The following is a description of a gene set: species: Mus musculus Mouse Gene Set: MIR_466I_5P from publication Chen Y, Wang X (PMID 31504780) Genes predicted to be targets of miRBase v22 microRNA mmu_miR_466i_5p in miRDB v6.0 with MirTarget v4 prediction scores > 80 (high confidence targets)., and this is the list of marker genes: Cd84, Mymk, Rhbdd1, Scaf11, Ddi2, Cnot7, Chst11, Slc8a3, Pdxk, Dcx, Rab11fip4, Irf2bp2, Clec4g, Zfp612, Fbxo31, Lbp, Ilrun, Tc2n, Gm14151, Slc4a8, Slc25a12, Nbeal1, Dusp7, P2ry13, Krt222, Triobp, Nufip1, Tvp23a, Pou3f2, Bach2, Asxl2, Hmga2 (high mobility group AT-hook 2), Ralb, Rasa2 (NCBI Gene Id 71394), Ms4a5, Pcdhgb6, Mdm2, Sowahb, Pcdhga3 (protocadherin gamma subfamily A, 3), Esf1, Pcdhgb7, Atrn, Has2, Zfp994, Scn8a, Slc10a2, Stxbp5, Slc25a21, Rara, Ccdc71l, Onecut2, Slc6a1, Ado, Pld5, Cnga4, Chic2 (cysteine-rich hydrophobic domain 2), Kirrel3, Zfp747, Esr2, Gm14325 (NCBI Gene Id 329575), Rbm34, Cask, Dhx40, Fam149b, Msrb3, Cyp4a31, Gabrb2, Egfl6, Dhdh, Unc5c, Prdm12, Lin7a, Wipf2, Spin1, Deptor, Acot2, Rab18, Camk1d, Rims2, Ccna2, Optc, Ogdh, Chrnb4, Plac9, Chd7, Septin11, Ttc38, Mtmr12, Hoxc13, Flrt1, Creb3l1, Snai2, Sema5b, Lcp2, Stxbp4, Pcdhga2, Atxn1, Cd300ld, Uvssa, Rnf44, Lrtm2, Cacna1e, Itga9, Pde10a, Rab6b, Sptlc2, Ddx19b, Kcnmb1, Sv2a (synaptic vesicle glycoprotein 2a), Acsl4, Cfap97, Vezt, Slc37a1, Homer2, Celf4, Onecut3, Cyth3, Ddo, Nqo2, Metrnl, Tmem236, Actr1b, Thsd4, Slc35a3, Ank2, Creg1, Tyw3, Pou2f2, Fubp1, Unc93a, Rfx3, Kcnip3, Smarca2, Peak1, Siah2, Myorg, Bltp3b, Apba1, Emx2, Sod2, Aptx, Dgkg, Sh2d2a, Ugt2b34, Oprm1, Xrcc3, Ubfd1, Zfp696, Vapb, Sbk3, Srgap3, Ttll1, Prdm6, Tmem132b, Dnase1l3, Glis3, Asap3, Slco2a1, Mr1, Acss1, D630003M21Rik, Rasal2, Gas2l3, Htt, Ptchd1, Mbnl3, Jmy, Trub2, Xylb, Acp3, Baiap2, Fgf23, Tmem150c, Rabl2, Pank1, Ptch2 (NCBI Gene Id 19207), Pcdhga10, Psd3, Tacr1, Zfp92, Cdh6, Ift57, Depdc5, Cdh20, Tgfa, Mapk6, Bgn, Jmjd8, Hnrnpa0, Srp9, Cd47, Man1c1, Zfp318, Ehd4, Sdf4, Ackr4, Cd99l2, Iglon5, Dlgap4, St8sia1, Galntl6, Pcdhgb1 (NCBI Gene Id 93699), Trim67, Mnt, Zfp266, Tnfrsf11a, Fzd3, Sp9, Vtcn1, Rab11fip1, Wscd1, Smyd3, Riok3, Gjc3, Prex2, Myo5a, Alox8, Baz2b, Kcnj1, Pcdhgb2, Nalf1, Frmd5, Capn6, Plxna2, Macroh2a2, Gm6710, Elavl4, Tead1, Pacsin2, Pou4f2, Enpp1, Tmem52b, Zfhx3, Trim30d, Zfp827, Ggt5, Ttc12, Arhgap26, Cldn34c1, D430019H16Rik, Pou6f1, Cmklr1, Pcdhga8, Gm3604, Zmat4, Bend3, Vsig10l, Ptpre, Zmiz1, Slc22a8, Wdr59, Irag1, Zfp39, Mbtd1, Otx1, Slc1a2, Sema5a, Kcnj15, Adhfe1, Stxbp5l, Mllt3, Prkca, Fermt1, Mrpl19, Lgals12, Prss42, 2510009E07Rik, Zfp607b, Nkain3, Dctd, Dapp1, Ubxn2b, 1110059E24Rik, Plp1, Sp100, Bmpr2, Liph, St8sia3, Elp4, Csmd1, Acvr2b, Egr3, Tamalin (trafficking regulator and scaffold protein tamalin), Atm, Adamts17, Vti1a, Cp, Usp25, Gadl1, Ebf3, Vamp5, Lcorl, Snrpn, Foxk1, Nrxn1, Gas2l1, Kpnb1, Treml2 (triggering receptor expressed on myeloid cells-like 2), Mlxip, Zfp831, Gria3, Cerk, Gask1a, Gucy2e, Kat6a, Ehd3, Tmem151b, Cryz, Tgfbrap1, Garem2, Ap1ar, Samd7, Hivep3, Slc31a2, Fsd1l, Zfp488, Kmt5b, Foxn1, Il1rap, Slc8a1 (solute carrier family 8 (sodium/calcium exchanger), member 1), Fam186b, Flt4, Adgrf5, Eif4e, Gabrq (NCBI Gene Id 57249), Vangl1, Fbrs, Wdr46, Gcnt4, Frk, Zfp663, Ostm1, Zfp606, Megf8, Rhobtb1, Gna13, 9330159F19Rik, Spx, Fam174b, C5ar2 (complement component 5a receptor 2), Pcdhgb8, Arih1, Gm4925, Snx12, Cstad, Septin6, Enpp6, Zfp691, Tpgs2, Slc38a6, Slc2a12, Rimkla, Tnfrsf13c (NCBI Gene Id 72049), Gm14434, Foxa1, Pitpnb, Nxpe3, Epha7, Cacna1c, Tfap2b, Gtf2h2, Ggact, Pdik1l, Clptm1, Alkbh7, Pogk, Chmp1b2, Adra1b, Pgbd1, Svip, Nrk, Mrps25, Pcdhga12, Bicd1 (NCBI Gene Id 319962), Pck2, Zfp365, Nkain2, Map3k7cl, Ceacam18, Pura, Gcnt1, Cacna2d4, Itsn1, Lyrm9, Bcl2l11, Dnai4, Polr3b, Znrf3, Rrm2b, Sox5, Peg3, Zfp37, Cyp2j12, Tti1, Tmod2, Glyr1, Slco3a1, Mfap3l, Oacyl, Smpd4, Lyz3, Nrip3, Ythdc2, Nrp2, Ccdc85a, Rab7, Unc13b (NCBI Gene Id 230089), Zfp74, Ermap, Cyp2g1, Ajap1, Brwd3, Ccdc115, Mbtps2, Prim2, Trpc6, Methig1, Tacc1, Arhgap25, Slc6a6, Rab9, Neurod2 (NCBI Gene Id 18013), Zdhhc21, Kcng3, Rabgef1, Elfn2, Rgs9bp, Rpp25, Trpm3, Rspo1, Nkap, Cfap74, Stk32a, Tafa3, Rfk, Eif2b3, Pik3r5, Trim60, Oxsm, Ncam1, Nt5e (5' nucleotidase, ecto), Vps37a, Dcdc2a, Gulp1, Pafah1b1, Dixdc1, Iars1, Crebl2, Srf, Cd19, Peli2, Acot4, Tafa1, Calcoco1, Pfkp, Fam169b, Muc4, Akap13, Aldh8a1, Mettl27, Prps1l1, Zc3h12d, Pou3f4, Desi2, Gatc, Borcs8, B4galt5, Gng2, Mdga1, Trim36, AI429214, Zfp91, Ago3, Ppp1r9a, Col13a1, Dlgap2, Barhl2, Asah2, Fndc7, Gnal, Zfp113, Adarb2, Terf2ip, Prkcg, Sema6a, Lrrc61, Ap3s2, Cradd, Rad18, Nr4a2, Aak1, Coq8a, Slc7a8, Vps33a, Mrap, Tmem18, Ms4a4c, 3425401B19Rik, Wars2, Plppr3 (phospholipid phosphatase related 3), Wiz, Yipf6, Golm2, Cplx2, Dph6, Wrn, Tsn, Dkk1, B4galt6, Prelid3a, Pcdhgb4, 2810021J22Rik, Gpr45 (NCBI Gene Id 98649), Apela, Hook3, Vegfb, Anks1b, Meis2, Zfp575, Nufip2, AW554918, Paics, Zbtb7b (zinc finger and BTB domain containing 7B), Rit2, Evi2b, Slc35e2, Mobp, Vsnl1, Kif5a, Slmap, Cnpy3, Cd2ap, Igsf6, Ctse, Ascl4, Dcakd, Zfp810, Prox1, Trip12, Spef2, Zyg11b, Garre1, Atg10, Slamf1, Ngfr, Erg, Iqgap2, Gm2026, Rorb, Zfp276, Slc25a31 (NCBI Gene Id 73333), Arid1b, Fbxw5, Cd27, Zfp446, Nfya, Stambp, Dnaaf5, L1cam, Sowaha, Kif1a, Pof1b, Il18r1, Magee2, Olig2, Scn5a, Grk3, Prokr2, Ttll7, Napepld, Npr3, Hycc2, Dhfr, Rusf1, Krt6b, Abcc9, Pcdhga1, Spock2, Rmi1, Meak7, Zscan29, Trim56, Bst1, Zfp174, Fgf11, Smo, Ctsc, Ddr1, Gm14391, B4galnt2, Steap2, Pecam1, Ubtf, Mylk4, Thada, Nat8f2 (NCBI Gene Id 93673), Fgfrl1, Sspn, P2rx7, Prc1, Nat8l, Trpc7, Pcdha4b, Lpp, Pstpip2 (NCBI Gene Id 383409), Nagpa, Hif1an, Zfp46, Pfn1, Casp6, Tubb4a, Lrrn4cl, Lnpk, Gid8, F830016B08Rik, Tppp, Pign, Hspg2, Ppp1r1c, Wnt4, Mrgpre, Pnma2, Klhl9, Ascl1, Cacna2d2, H2-M2, Sike1, Cplx3, Adgra1, Cyb5b, Slc16a5, Igf2, Iars2, Il22ra1, Cd33, Igf2bp2, Tgfb2, Adcy1, Cdc6, Heatr6, Zfp516, Sv2b, Slc5a8, Nfat5, Kcna7, Muc13, Knstrn, Ints10, Cdk5r1, Rnf220, Rgr (NCBI Gene Id 57811), Ccdc3, Bard1, Pdcd4, Pcdhgb5, Tet2, Shisal1 (shisa like 1), Iffo2, Accs, Pdzrn3, Neu1, Sri, Adamts14, Alg12, Kcnv2, Tenm2, Setd3, Actr10, Cdk6, Dnah17 (dynein, axonemal, heavy chain 17), Fzd7, Vwa5b2, Snap23, Osr1, Nhsl1, Kcna2, Dnlz, Proser3, Arhgef9, Pcdhga7, Sh2b3, Plxdc2, Med14, Prkn, Camta1, Elavl3, Igf1r, Draxin, Scd3, Arhgef17 (Rho guanine nucleotide exchange factor 17), Man2a2, Slu7, Ncam2, Rfx7, 1810065E05Rik, Gm4724, Gm12886, Eda2r, Mtus2, Elovl6, Eogt, Klhl13, Nipal1, Acox3, Pcdh10, Acsm2, Cdk13, Galnt13, D630023F18Rik, Jarid2, Ubap2l, Chst2, Synj2bp, Sh3rf3, Gabrg2, Pcdhga5, Art1, Brinp2, Angpt2, Cer1, Itga3, Csrnp2, Foxl1, Nkx2-9, Hoxb4, Gm5141, Chrnd, Kdm6b, Ulk1, Evx2, Glra1, Porcn, Cygb, Htra4, Ano3, Naip6, Gabrb3, Epha4, Pirt, Zkscan1, Reps2, Gcm2, Bcor, Nphp3, Prr18, Kmt5a, Plekhg5, Tnpo3, Rreb1, Phactr3, Nab2, Lsm1, Cgnl1, Adtrp, Cbln3, Arhgdib, Kcnq2, Kif3a, Marchf1, Prpf4, Greb1, Mical2, Wipf3, E2f8, D630039A03Rik, Cstpp1, Pakap (NCBI Gene Id 97198), Slc22a15, Rpusd2, Supt7l, Ric8b, Klhl23, Mfsd6, Slc7a1, Cd4, Kank2, Ppih, Ugcg, Tmem47, Fcrl6 (Fc receptor-like 6), Rnf170, Pde1c, Trpc5, Astn1, Cds2, Map3k7, Rora, Nwd1, Pigh, Pcdh17, Insyn2a, Cdh7, Pcdhga11, Prr11, Cend1, Mcidas, F10, Gpr173, Ralgapa2, Rnft1, Dtx3l, Zfand5, Gbp7, Atg7, Rrm2, Ncoa2, Ttc14 (NCBI Gene Id 99698), Clec2l, Pcdhgc4, Sec14l4, Slc39a14, Igfbp3, Ufm1, Tmem141, Scn2a, Runx3, Mindy2, Dclk1, Hexim2, Cd28, Zfp239, Tmtc3, Glce, Elovl5, Ccdc125, Ipcef1, Cstf3, Ap1g1, Tent5a, Katnal1, Lrrc32, Igf2r, Ankrd34a, Eef2k, Slc24a2, Ceacam2, Pgrmc1, Gm14308, Flnb, Adam12, Mon1b, Abce1, Oxtr, Srxn1, Cox15, Wars1, Urod, Ski, Alpl, Ssbp4, Cyfip1, Brix1, Tnr, Papss2, Gm38666, Col19a1, Gnaz, Cd274, Pclo, Pitpnc1, Mettl21e, Cxcl12, Serinc3, Kcnn3, Nlgn3, Ifi44, Ewsr1, Phf1, Ppfia2, Tirap, Btbd8, Tigd5, Bptf, Atp2b3, Fech (ferrochelatase), Rgs4, Fig4, Doc2b, Itga4, Zfp712, St18, Map3k20, Tmem178b, Gls, Efna5, Csf2ra, Maea, Acot3, Apbb2, Rgs5, Zfp936, Septin3, Bean1, Acp1, Tor3a, Klf6, Slc4a4, Sin3a, Napb (N-ethylmaleimide sensitive fusion protein attachment protein beta), Rnft2, Tmco1, Cnih3, Lims1, Diaph2, Cxcl15, Nedd4l, Ptgdr, Plpbp, Clvs1, Pappa, BC030500, Gfpt1, Cntn2, Prxl2a, Sdr42e1, Nmrk2, Extl3, Ddx51, Endov, Sox12, Glra2, Prkci, Sox7, Zfp68, Dio2, Rnpc3, Setd7, Btbd3, Cmc2, Runx1t1, Mblac2, Gnat1, Srsf12, Ino80d, Irgm2, Nck2, Orai2 (NCBI Gene Id 677007), Prr5l, Cdc42ep4, Ifnlr1, Ptpn14, Ttc39b, Fam171a1, Kcnk10, Trim12c, Tmem104 (NCBI Gene Id 320534), Mafb, Cipc, Mmp28, Urb2, Plcb1, Psg29, Tph1, Ptgfr, Prss59, Scn3b, Baalc, Atp11a, Zfand2a, Slc6a17, Rsf1, 1700025G04Rik (RIKEN cDNA 1700025G04 gene), Carm1, Rab2b, B3galt6, Chic1 (NCBI Gene Id 331484), Psd2, Ly6g6c, Micu2, Cgas, Xpr1, Gm14137, Nid1, Ints8, Sys1, Gata4 (NCBI Gene Id 14463), Pcdhga6, Gpr68, Pcdhgc5, Mlec, Rhou, Trem1, Pgap1, Zfp655, Usp45, Syt15 (synaptotagmin XV), Zfp449, Cyb5r3, Slc17a5, Dlg4, Fbxo30, Rp1, Syn3, Hck, Meltf, Coro2b, Katnip (NCBI Gene Id 272436), Shisa6, Six6, Hrh1, Pard3b, Zfp248, Pappa2, Ttc4, Cdc27 (cell division cycle 27), Efcab14, Kcnb1, Cpm (carboxypeptidase M), Acvr2a, Lcmt2, Ceacam1, Dock5, Tacr2, Runx1, Ece1, Net1, Cox10, Dcaf17, Stat6 (signal transducer and activator of transcription 6), Mta3, Tmem200a, Rab3c, Nsun3, Camk2a, Unc5a, Brinp1, 9030624G23Rik, Lnx2, Lratd1 (LRAT domain containing 1), Cnksr2, Stard8, Dhh, Nrbp2, Tmem26, H2bc6, Gng12, Zfp799, Zfp169 (zinc finger protein 169), Xk, Itgam, Opcml, Cox16, Tns1, Cdc37l1, C1ql3, Mmab, Chn1, Tcaim, Sparc (secreted acidic cysteine rich glycoprotein), Ptprb, Zfp976, Lipe, Rgs17, Slc48a1, Fam107a, Hdac8, Zeb2, Dse, Lrrc18, Cflar, Edaradd, Zfp641, Cap2, Sarm1, Tnrc6c, Uncx, Slc30a10, Maml3, Grik3, Chst3, Micall1, Trim65, Dlg1 (NCBI Gene Id 320792), Snurf, Ssr1, Nmrk1, Tlx1, Asb13, Aldh5a1 (NCBI Gene Id 74423), Bdh1, Pcdhga4, Prkaa1, Insr, Cat, Tbc1d30, Nos1, Unc5d, Prlr, Lclat1, Mga, Nab1, Dppa1, Rnf150, Kcnc1, Fbxl17, Casp8, Lhx5, Nmnat2, Pcdhga9, Prrc2b, Havcr2, Zrsr2, Fat3, Fbxw28, 1700028K03Rik, Rassf2 (NCBI Gene Id 99374), Pcdhgc3, Sh3bp5, Ubxn2a, Bdp1, Arpp21, Thsd7a, Srpx2, Fblim1, Tktl2, Nav1, Sipa1l1 (signal-induced proliferation-associated 1 like 1), Bnc2, Tbx15, Mex3a, Avl9, Chrdl1, Vipr2, Gdpgp1, Loxl4, B3gnt9, Mocs1, Nudt13, Mgat4a, Mecp2, Ctdsp2, Gabra2, Zfp764, Coq5, Sh3bgrl2, Ube2q1, Ildr2, Atp2b2, Rslcan18, Map7d1, Rnasel, Trmt2b, S2bpcox16, Cd160, Pate9, Cdh12, Zfp329, Deup1, Tub, Tcp11l1, Creg2, Tcte1, Mapk11, Pfkfb2, Zfp1008, Fmn2, 4921509C19Rik, Slc35d2 (NCBI Gene Id 70484), Tmt1a3, Dcun1d1, Mcu, Nfasc, B3galt1, Lrat, Zfp704, Pilra, Pcmtd1, Prkcb, Idua, Sox1, Gabbr1, Mapk8, Klf12, Senp1, Cmah, Prss23, Fndc3a